The following is a description of a gene set: studied in species Homo sapiens Human Gene Set: AIZARANI_LIVER_C34_MHC_II_POS_B_CELLS from publication Aizarani N, Saviano A, Sagar, Mailly L, Durand S, Herman JS, Pessaux P, Baumert TF, Grün D (PMID 31292543), and this is the list of marker genes: CD22, RPS5, CLN8, IQSEC1 (IQ motif and Sec7 domain ArfGEF 1), PCDH9, TCL1A, ARL10, NAP1L1, CORO1A, FCRL2, SLC9A7, CLEC2D, LINC00926, EEF1B2, LUC7L3, ISG20, TMEM154, RPS11, MKNK2, CYBB, BCL11A (NCBI Gene Id 55085), LYN, RCSD1, AEBP1, FCMR, FCRL1, FOXP1, DGKD, SMAP2, CNTRL, PLAC8, EEF2, CD37 (CD37 molecule), ATF7IP (activating transcription factor 7 interacting protein), GNG7, RNASET2, LYST, EGR3, ARHGEF18, CD52, LTB, NCF1, RALGPS2, BACH2, BICD2, EVI2B, HSH2D, RIPOR2, LAPTM5, RPL19, TNFRSF13C, ORAI2, SWAP70, NCOA3, RHEX, RNASE6, FCRLA, YBX3, ATP2B1, RPS8, BOD1L1, SP140, NIBAN3, CD1C (CD1c molecule), MTPN, RPL39, PRKCB, FAU, HLA-DRB5, SEPTIN6, RPL18A, DDX6, RUBCNL, LIMD2, PTPN6, P2RX5, CXCR4, TLR10, SPIB, CD83, PARP1, PAX5, CLCN6, VPREB3, SELL, KIAA0040, HLA-DQB1, TLR6, HLA-DRB1, AFF3, HLA-DPB1 (major histocompatibility complex, class II, DP beta 1), RPL18, ITM2C (NCBI Gene Id 9523, integral membrane protein 2C), EBF1, MAP3K8, MS4A1, BANK1, PARP15, PLEKHA2, SYK, PPM1K, IL4R, CD79A, RPS27, CD79B, MDM4, SF1, KLF2, GABPB1-AS1, CCR7, POU2F2, UCP2, MARCHF1, POU2AF1 (NCBI Gene Id 5450), MAP3K1, STX7, TTN, HLA-DQA1, RPS23, BIRC3, CD19 (NCBI Gene Id 930), PDE7A, DOK3, CIITA, RPLP2, CXXC5, MPEG1, CYFIP2, HLA-DRA, PTPRCAP, RPL13A, IRF8, CAMK1D, CD82